Given this list of marker genes CCR1, IL12A-AS1, C4A, HLA-DRB1, IL12A, ERAP1, IL10, KLRC4, LACC1, IL6, UBAC2, HLA-B (NCBI Gene Id 730410), IL23R, IFNGR1, MEFV, TLR4, FAS (NCBI Gene Id 355), STAT4, MIF, here is a description of the gene set: species: Homo sapiens Human Gene Set: HP_NON_INFECTIOUS_MENINGITIS Non-infectious meningitis Inflammation of the layers of tissue that cover the brain and spinal cord (meninges) and of the fluid-filled space between the meninges (subarachnoid space) when it is caused by disorders that are not infections or by drugs or vaccines.